Given this list of marker genes DFFB, ANKLE1, NUDT16L1, RNASEH2A, RNASE6, DROSHA, RPP38, MRE11, PGBD5, ASTE1, DNA2, ENDOU, POP1, ERN2, RBBP8, RPPH1, ENDOG, DNASE1L1, APLF (aprataxin and PNKP like factor), OGG1, TSNAX, SND1, RPP40, ELAC1, PPP1R8, RNASE7, POP7, AGO1, KHNYN, CWF19L1, RNASEH1, ERCC5, PLD6, RIDA, RCL1, RNASE2, FAN1 (FANCD2 and FANCI associated nuclease 1), MBLAC1 (metallo-beta-lactamase domain containing 1), RPP25, NOB1, DBR1 (debranching RNA lariats 1), PIWIL4, GEN1, NTHL1, PXDNL, POP5, PRORP (protein only RNase P catalytic subunit), SLFN13, EME2, XRCC3, RNASE3, AGO4, EXOG, ZC3H12A (zinc finger CCCH-type containing 12A), AGO2, PNKP, BIVM, FEN1 (NCBI Gene Id 5882), MUS81, MGME1, TSEN34, ZC3H12D, NUDT16, NUDT12, YBEY, DNASE1L3, ERN1 (NCBI Gene Id 63433), RAD51C, RAD50, APEX1, APEX2, SLX1A, LACTB2, RNASET2, TSEN2, RNASE1, ELAC2, XRCC1, RAG1, ENDOD1, DNASE1, RPS3, RNASE4, SETMAR, RNASE8, DNASE1L2, PIWIL2, PIWIL3, RPP21, TEFM, SLFN14, INTS11, CPSF3, RNASEK, TSN, PIWIL1, POP4, ZC3H12C (zinc finger CCCH-type containing 12C), ERCC4, N4BP2, ZC3H12B, MBD4, DICER1, RPP30, AGO3, RNASEL, ZRANB3, G3BP1, EME1, ENDOV, DNASE2B, NYNRIN, SLX1B, EXO1, SMG6, PMS2, RPP14, MRPL44, ERCC1, ANG (angiogenin), DNASE2, SLFN11, ANKZF1, DCLRE1C, DIS3, ABCE1, REXO4, TMBIM6, LAS1L, RNASE11, here is a description of the gene set: studied in species Homo sapiens Catalysis of the hydrolysis of ester linkages within nucleic acids by creating internal breaks. Human Gene Set: GOMF_ENDONUCLEASE_ACTIVITY